The following is a description of a gene set: from publication Chen Y, Wang X (PMID 31504780) Genes predicted to be targets of miRBase v22 microRNA mmu_miR_12184_5p in miRDB v6.0 with MirTarget v4 prediction scores > 80 (high confidence targets). studied in species Mus musculus Mouse Gene Set: MIR_12184_5P, and this is the list of marker genes: Mcm3ap, Ep300, Postn, Slc17a6, Spp1, Dennd1b, Kbtbd7, Hdgfl3, Gria3, Birc6, Baiap2l1, Zfp800, Apaf1, Rapgef6 (Rap guanine nucleotide exchange factor (GEF) 6), Clasp1, Il12b, Tshz3, Rfx3 (NCBI Gene Id 320548), Plcxd3, Scn3a, Tmem59 (NCBI Gene Id 76986), Efr3a, Pdcd6, Deptor, Lefty1, Csde1, Nadk2, Tmtc4 (transmembrane and tetratricopeptide repeat containing 4), Rictor, Foxo3, Fbxl14, Poldip2, Tpk1, Slc17a4, Zeb2, Ssbp3, Rap2a, Luzp2, Ubac2, Bcl7a, Mbtd1, Kcmf1, E130308A19Rik, Gatm, Alkbh5, Fam76b, Lgals8, Klf12, Bcap29, Camk2d, Nkain3, Ywhah, Kera, D430041D05Rik, Ttll7, Mtpn, Fgf9, Setbp1, Spry4, Rora, Smim13, Pcdh19, Sec23ip, Hmgn3, Satb1, Ctps2, Six6, Pdgfra (NCBI Gene Id 231312), Cul4b, Crtc1, Ubqln2, Dlg2, Utp14b, Lrguk, Med1, Camta1, Cpeb2, Gna14, Hps6, Agbl3, Hey2 (hairy/enhancer-of-split related with YRPW motif 2), Adgrl2, Sar1b, Sh3bgrl, Pak5, Sult1a1, Vegfc, Pum2, Cnih1, Map3k8, Pcdhb13, Arid1a, Trp63, Nova1, Phf21a, Rps6kb1 (ribosomal protein S6 kinase, polypeptide 1), Oxgr1, Ptpn21, Kcnmb2, Vezf1, Zfp275, Zbtb2, Kcnd3, Abcg4, Smad7, Pard3, Tnrc6c, Kcnj3, Psd3, Vmn1r63, Ino80d, Zdhhc2, Arhgap27, Erich4, Prkca, B3galt2, Abhd3, Kdsr, Fkbp5, Pir, Atl1, Axin1